Given this list of marker genes CHRNA4, CHRNG, CHRND, CHRNA3, CHRNB2, CHRNB4, CHRNE, here is a description of the gene set: Nicotinic acetylcholne receptors that have low Ca2+ permeability allow the influx of Na+ which causes depolarization of the membrane initiating voltage dependent responses such as activation of voltage dependent opening of Ca2+ channels and thus eliciting an increase in Ca2+ and downstream signaling. These receptors could be found in both presynaptic and postsynaptic terminals. Reactome Pathway: Highly sodium permeable postsynaptic acetylcholine nicotinic receptors part of: Postsynaptic nicotinic acetylcholine receptors; Presynaptic nicotinic acetylcholine receptors studied in species Homo sapiens